Given this list of marker genes TTC1, EDEM1, ZNF585B, DLG1, COMMD3, QSOX1, ERCC6L2-AS1, CLPTM1, REXO2, DPM3, POLR2L, PDF, NMT1, FBXO9, PDIA6, TERF2, CNOT6, NPHP3, PLPP5, PYCR2, LMAN1, ARF1, TBCE, GTF2H1, IGHA2, DENND2D, TNFRSF17, ENSG00000272447 (NCBI Gene Id 642361), SPCS2, GATAD1, CAV1, POC5, ACSL5, SLAMF6, PBRM1, PABPC1L (NCBI Gene Id 80336), POLR2J2, H4C12, GMDS, TSC1, NVL, NSD2, DPP3, HIKESHI, PDIA4, HM13, ALG14, COPZ1, ZNF512, MAP3K7, ZNF573, PDHA1, METTL3, IGLL1, TCF7, SLAMF1, IGLV3-19, KRIT1, IARS1, MZB1, DTD2, TCTN2, IPP, ADSL, TRRAP, BRCC3, FBH1, LMAN2, TCF12, NBPF1, KDELR1, C6orf89, SLC44A1, SRSF1, ELP5, ARF4, HFE, FLI1, CNOT1, C1GALT1C1 (NCBI Gene Id 29071), TRIM73, ATP6V0A2, FBXW7, ECE1, KLHL14, ZNF207, PPP1R21 (protein phosphatase 1 regulatory subunit 21), PLPBP, ACADM, PSMC3, COX18, MANF, STAT5B, THEM4, CUTC, FAM85B, ANXA6, SNORD104, NOMO1, NFATC2IP, HMG20B, GRAP, PCLAF, BLOC1S5, HYOU1, WIPI1, SSR1, SETD5, ZNF692, RPS27A, AIFM1, FCMR, MCCC2, PRIMPOL, MID1, DNAAF10, NUP37, ZNF818P, MTDH, ESYT1, UGGT1, FAM120B, ALG5, ENTPD1, MTMR4, UBXN8, GIMAP1, HERC2, TTC17, RABAC1, LXN, SLC30A7, FLAD1, GPAA1, TMEM258 (transmembrane protein 258), EPRS1, TRAF5, NUP210, NOMO2 (NODAL modulator 2), HIPK2, IGHG4, MRPL24, S100PBP, HECA, TAF12, UBASH3A, ALG8, MRPL23, SRM, SLC33A1, ARIH2, ITM2C, ST6GAL1, TMC6, IGHV1-69, UPF3A, KCNK6, CREBZF, MFNG, MRTO4, DHRS4-AS1, PIGU, CNPY2, BET1, CLK2, OCIAD1, NDUFAF3, INPP4A, ERLEC1, TMEM214, TIMMDC1, GCN1, SRPRB, ASB3, ITGB7, KDELR2, NDUFC1 (NCBI Gene Id 4717), UCP2, SNORA28, OGFOD1, NSUN5, UXS1, MLEC, NDST1, IGLV2-23, ERGIC2, IGHG1 (NCBI Gene Id 3500), OSTC, PAAF1, KRTCAP2, NSUN5P1, RBM6, C11orf54, VPS29, TMED9, ADK, MRPS31 (NCBI Gene Id 112759), GLT8D1, SPTBN1, IMMT, TMEM156 (NCBI Gene Id 80008), CDC16, MRPL37, TMEM19, RBM41 (NCBI Gene Id 80171), FARSB, CHCHD7, FKBP11, MAD1L1, TMEM165 (NCBI Gene Id 55858), GART, TMEM204, PIK3C2A, IGLV1-44, TRUB2, ORMDL1, COA5, NIPAL3, TXNDC5, TAPBPL, ACAT1, TRIM52, JCHAIN, FKBP2, PHKB, FAM120AOS, IGLV3-25, MRPS7, DNAJB11, FTX, MARK2, RPA3, GMPPB, ZBTB8OS, CRLS1, POLR2H, RAI1, ZKSCAN1, LARP4B, HEXA, EBNA1BP2, LDLRAP1, DHPS, TRIB2, MTNAP1, ELP3, HAX1, PAQR8, MFSD8, SSR3 (signal sequence receptor subunit 3), CLN5, PRDX4, MS4A1, CD27, NUDT5, EAF2, P4HB, HDDC2, IGHG2, GTF2A2, ZNF318, SLC30A6, ATF6, ECHDC2, PRDM15, SEL1L, IGHD, NNT, COA4, SLC30A5, CEP350, MRPS18A, CDK13 (NCBI Gene Id 8621), ANKRD36B, MTRF1, TYMS, MAN1A1, RER1, DNAJC1, NPAT, SYNRG, ADAM19, COBLL1, ZDHHC13, IGHM, SUB1, FDPS, OGDH, ACSS1, NCL, NT5DC1, SPIN3 (NCBI Gene Id 169981), MTHFD1 (methylenetetrahydrofolate dehydrogenase, cyclohydrolase and formyltetrahydrofolate synthetase 1), UBAP2, SETDB2, METTL8, MRPL34, SAMM50, DDOST, OSBPL10, PPIB, ZNF514, POLR3A, GPATCH1, NDOR1, PMS2P2, HIBCH, NT5C2 (5'-nucleotidase, cytosolic II), FKBP14, UBE2G1, CD79A, EIF2B4, LSM4 (LSM4 homolog, U6 small nuclear RNA and mRNA degradation associated), NMRAL1, HERC4, IGHV3-48, MED16, RRM2, ZNHIT1, IGKC, ATXN2, VPS8, GPR75, EEF1A1, SDF2L1, DCPS, PRKCI, KIF3B, CALU, CD79B, DZIP3, QRSL1, LRCH3, MTIF3, ANKZF1, NMRK1, PGM5-AS1 (PGM5 antisense RNA 1), MEGF6, UBE2J1, IGLC1, CASP2, FUS, CAMK2G, IKBKB, SPOP, PREB, IGHA1, IPO9, TPD52, MCM7, HS2ST1, TNFRSF13B, ZNF638, METTL2B, IGHV3-23, PI4KB, SMC4, SP3, PSME3IP1, APOBEC3B, ANG, KRBOX5, MFF, USP45, C11orf24, PDIA5, KRI1, PNOC, ZNF717 (zinc finger protein 717), TUBD1, RAD17, USP28, COPB2, IL2RA, HDLBP, PSME3, KDSR, INPP5B, GTPBP3, ATP8B2, RPRD1A (regulation of nuclear pre-mRNA domain containing 1A), AQP3, BATF (NCBI Gene Id 10538), HSP90B1, HERC2P3, SEC24A, VAMP1, IL6R, STING1, SNRNP25, TXNDC15, IGKV1D-33, RBM5, KLHDC10, PAICS, AURKAIP1, DGUOK, PRKDC, SAR1B, G3BP1, PSMB5, HBS1L, KHDC4, C2orf68, YIF1A, NUDT9, LPXN, GEMIN7 (NCBI Gene Id 79760), NSUN5P2, UBA5, LRIG2, GTF2H2, GNPAT, PPP6R3, MCTS1 (MCTS1 re-initiation and release factor), RPN1, ANAPC7, BCAT2, H1-3, EMSY, APEH, METTL25, ATG7 (autophagy related 7), MDS2, CASP6, MRPS16, P2RX5, AK2, ANKRD17, TMBIM4, WASHC3, IGLL5, COG8, SPCS3, HDDC3, PIGF, SNX19 (sorting nexin 19), MYDGF, PCED1B, LUC7L, IFFO1 (NCBI Gene Id 25900), VAPA, AARSD1, PRMT1, GOT1, NUP43, C9orf85, NAA20, SHMT2, PTPRCAP, CPSF2, PFDN6, NCOA3, POU2AF1, LDAH, MTAP, IGLV3-16, STT3A, TOR3A, LINC01138, CD59, DPEP2, PRIM1, GOLGA5, SPATS2, FAM30A, PCID2, TMEM223, CBFA2T2, PLA2G6, PRPSAP1, GLCCI1, PPP1R3E, PILRB, GGH, SLAMF7, OGT, SLC35B3, MITD1, CLPTM1L, L3MBTL2, RNF34, RAB3GAP1, COPG1, EIF3J, NAIP, MPHOSPH9, SEC23B, EDEM3, ATIC, SEC61A1, C1orf56, JPT2, BLNK, CLCC1, MON2, NIPSNAP1, TIMM13, SIRPG, PHB1, MCM3, ZWINT, TMEM260, SLC35E2A, TFB1M, VRK3, PMS1, KIAA1143, FASTKD1, EIF3M, HINT2, USO1, FCRL5, SLC26A2, RALGAPB, MRPS33, MED17, MRI1, CDC25B, CD38, WDR46, USP48, PDCD11, EDF1, AARS1, RPN2, MIAT, MRPS18B, STYX, IGKV3-20, SNAPC5 (small nuclear RNA activating complex polypeptide 5), BLTP2, SEL1L3, IGHV4-31, FAHD2A, HIRIP3, CREB3, ANTXR2, TBC1D14, SUPT20H, NIT1, RAB3GAP2, FAM3C, MRPL41, UQCRQ, STK38, COPE, GALM, COPS6 (NCBI Gene Id 10980), SEC11C (NCBI Gene Id 90701), CREB3L2, TNIP1, ZMYM5, ORC3, FAM200B, CSTF3, PIGP, ZFX, IGHG3, ISG20, MSS51, COMMD1, TRAM2, ECHDC1, IDH2, TRAPPC12, POP5, FBXL16, SRP54, UBE4B, H4C11, HACD3, METTL2A, here is a description of the gene set: from publication Nakaya HI, Wrammert J, Lee EK, Racioppi L, Marie-Kunze S, Haining WN, Means AR, Kasturi SP, Khan N, Li GM, McCausland M, Kanchan V, Kokko KE, Li S, Elbein R, Mehta AK, Aderem A, Subbarao K, Ahmed R, Pulendran B (PMID 21743478) Genes up-regulated in peripheral blood mononuclear cell 7d vs 0d in adults (18-50) after exposure to Fluarix/Fluvirin, time point 7D. Comment: Supplementary Table 1b: All the differentially expressed genes identified in PBMCs of TIV vaccinees. Here we have used a systems biology approach to study innate and adaptive responses to vaccination against influenza in humans during three consecutive influenza seasons. We studied healthy adults vaccinated with trivalent inactivated influenza vaccine (TIV) or live attenuated influenza vaccine (LAIV). TIV induced higher antibody titers and more plasmablasts than LAIV did. In subjects vaccinated with TIV, early molecular signatures correlated with and could be used to accurately predict later antibody titers in two independent trials. Notably, expression of the kinase CaMKIV at day 3 was inversely correlated with later antibody titers. Vaccination of CaMKIV-deficient mice with TIV induced enhanced antigen-specific antibody titers, which demonstrated an unappreciated role for CaMKIV in the regulation of antibody responses. Thus, systems approaches can be used to predict immunogenicity and provide new mechanistic insights about vaccines. species: Homo sapiens Human Gene Set: NAKAYA_PBMC_FLUARIX_FLUVIRIN_AGE_18_50YO_7DY_UP